The following is a description of a gene set: Human Gene Set: WP_16P1311_COPY_NUMBER_VARIATION_SYNDROME species: Homo sapiens 16p13.11 copy number variation syndrome, and this is the list of marker genes: PAFAH1B1, ACTR1B, MYH11, CEP170, OFD1, ABCC6, NDE1, MPV17L (NCBI Gene Id 255027), DCP1A, BMERB1, KIAA0753, GATA3, RAP1A, ACTR10, ABCC1, MARF1, DISC1, RAPGEF4, CEP20, PLAG1, ACTR1A, CEP170P1, DCP2, DCTN6, PLAGL1, PLK1, DCTN1, PCM1, DCTN4